Given this list of marker genes FZD4, GHRL, CRHR1, WNK4, KDM5B, KCNK9, REN, NKX3-1, TAC1, TSPO, CRY2, AGT, C1QTNF1, RETN, DAB2, PTPN11, SELENOM, INHBA, GDF9, CRH, CRY1, SPP1, GALR1, ECRG4, KCNQ1, GAL, BMP6, AGTR1, POMC (proopiomelanocortin), CYP19A1, here is a description of the gene set: Human Gene Set: GOBP_STEROID_HORMONE_SECRETION The regulated release of any steroid that acts as a hormone into the circulatory system. studied in species Homo sapiens